Given this list of marker genes CYB5B, CAV1, LYPLA1, SPR, WASL, NOS3, ZDHHC21, NMT2, DDAH1, CYGB, NMT1, AKT1, DNM2, CALM1, HSP90AA1, NOSIP, NOSTRIN, here is a description of the gene set: part of: Metabolism Nitric oxide (NO), a multifunctional second messenger, is implicated in physiological processes in mammals that range from immune response and potentiation of synaptic transmission to dilation of blood vessels and muscle relaxation. NO is a highly active molecule that diffuses across cell membranes and cannot be stored inside the producing cell. Its signaling capacity is controlled at the levels of biosynthesis and local availability. Its production by NO synthases is under complex and tight control, being regulated at transcriptional and translational levels, through co- and posttranslational modifications, and by subcellular localization. NO is synthesized from L-arginine by a family of nitric oxide synthases (NOS). Three NOS isoforms have been characterized: neuronal NOS (nNOS, NOS1) primarily found in neuronal tissue and skeletal muscle; inducible NOS (iNOS, NOS2) originally isolated from macrophages and later discovered in many other cell types; and endothelial NOS (eNOS, NOS3) present in vascular endothelial cells, cardiac myocytes, and in blood platelets. The enzymatic activity of all three isoforms is dependent on calmodulin, which binds to nNOS and eNOS at elevated intracellular calcium levels, while it is tightly associated with iNOS even at basal calcium levels. As a result, the enzymatic activity of nNOS and eNOS is modulated by changes in intracellular calcium levels, leading to transient NO production, while iNOS continuously releases NO independent of fluctuations in intracellular calcium levels and is mainly regulated at the gene expression level.<p>The NOS enzymes share a common basic structural organization and requirement for substrate cofactors for enzymatic activity. A central calmodulin-binding motif separates an NH2-terminal oxygenase domain from a COOH-terminal reductase domain. Binding sites for cofactors NADPH, FAD, and FMN are located within the reductase domain, while binding sites for tetrahydrobiopterin (BH4) and heme are located within the oxygenase domain. Once calmodulin binds, it facilitates electron transfer from the cofactors in the reductase domain to heme enabling nitric oxide production. Both nNOS and eNOS contain an additional insert (40-50 amino acids) in the middle of the FMN-binding subdomain that serves as autoinhibitory loop, destabilizing calmodulin binding at low calcium levels and inhibiting electron transfer from FMN to the heme in the absence of calmodulin. iNOS does not contain this insert. Originally identified as endothelium-derived relaxing factor, eNOS derived NO is a critical signaling molecule in vascular homeostasis. It regulates blood pressure and vascular tone, and is involved in vascular smooth muscle cell proliferation, platelet aggregation, and leukocyte adhesion. Loss of endothelium derived NO is a key feature of endothelial dysfunction, implicated in the pathogenesis of hypertension and atherosclerosis. The endothelial isoform eNOS is unique among the nitric oxide synthase (NOS) family in that it is co-translationally modified at its amino terminus by myristoylation and is further acylated by palmitoylation (two residues next to the myristoylation site). These modifications target eNOS to the plasma membrane caveolae and lipid rafts. <p>Factors that stimulate eNOS activation and nitric oxide (NO) production include fluid shear stress generated by blood flow, vascular endothelial growth factor (VEGF), bradykinin, estrogen, insulin, and angiopoietin. The activity of eNOS is further regulated by numerous post-translational modifications, including protein-protein interactions, phosphorylation, and subcellular localization. <p>Following activation, eNOS shuttles between caveolae and other subcellular compartments such as the noncaveolar plasma membrane portions, Golgi apparatus, and perinuclear structures. This subcellular distribution is variable depending upon cell type and mode of activation. <p>Subcellular localization of eNOS has a profound effect on its ability to produce NO as the availability of its substrates and cofactors will vary with location. eNOS is primarily particulate, and depending on the cell type, eNOS can be found in several membrane compartments: plasma membrane caveolae, lipid rafts, and intracellular membranes such as the Golgi complex. Reactome Pathway: Metabolism of nitric oxide: NOS3 activation and regulation studied in species Homo sapiens